The following is a description of a gene set: The chemical reactions and pathways involving aspartate, the anion derived from aspartic acid, 2-aminobutanedioic acid. Mouse Gene Set: GOBP_ASPARTATE_METABOLIC_PROCESS species: Mus musculus, and this is the list of marker genes: Adss2, Aspa, Got1, Got2, Got1l1, Ass1, Ddo, Adss1, Nat8l, Slc38a8